Given this list of marker genes RPA2, ARHGEF12, SNX10, ATOH1 (atonal bHLH transcription factor 1), ZC3H7A (zinc finger CCCH-type containing 7A), CCDC146, CXCR6, HAVCR2 (hepatitis A virus cellular receptor 2), LONRF3, GABBR1, PROS1, ERN1, PLEKHM3, TBX21, SLC2A3, MMP25, PRDM1, FCGR2B, RPL39L, XDH, RHBDF2, MYO1F, DOCK5, HOPX, POLK, GPHN, GNGT1, PTPRJ, TTC39C, ZEB2, LPIN1, ALCAM, TEF, SLC33A1, CADM3, ATP2B4, ATXN1, IFNAR2, COBLL1, RDM1, ITGA4, CX3CR1, PRF1, RUNX2, ESM1, MICAL2, ITGB2 (integrin subunit beta 2), KLRC2, LATS2, LGALS3, KIF5C, ITGB1, MS4A4A, NEBL, DAPK2, HDHD5, SMYD1, EEA1, IL18RAP, ITGA1, CCR2, FRRS1, GVINP1, IKZF3, GSAP, ITGAM, GNPTAB (NCBI Gene Id 79158), OSBPL3, NRP1, NFIL3, IFNG, PFKP, RAP1B, STARD10, DCLRE1A, ADGRE5 (adhesion G protein-coupled receptor E5), NKG7, KLRC3, CYRIA, MYADM, BHLHE40, ITGAL, ARRDC3, F2RL2, GNA15, CALM2, MIR202, GIMAP4, AHNAK, HIP1, MYO5A, ANXA1 (NCBI Gene Id 301), ARHGAP18, RSU1, CYTH4, RORA (RAR related orphan receptor A), MLKL, H2AZ1, SEPTIN10, TSPAN2, ZDHHC2, ARL15, EBPL, TMEM65, PTBP2, XYLT1, KCNJ8, SMPDL3B (sphingomyelin phosphodiesterase acid like 3B), EHBP1L1, VIM, ID2, GZMK, GSPT2, CMKLR1, SOAT2 (NCBI Gene Id 8435), MOSPD1, FGL2, LRRK1, PCGF2, WDR49, TMEM37, FIBP, CYFIP1, TNFRSF1B, EMP1, CCDC50, GPRIN3, CHIC1, CYP17A1, ITGAX, IL12RB2, RGS1, CDC20B, TMEM163, PIK3CG, IL2RA, TRIM46, CHPT1, ARSB, CTSD, EMP3, CD226, CCL5, KLRK1, CD44, ELL2, RNF216, TTC7B, BCL2L1, L1CAM, TOB2, CDHR1, CCL4, SRCIN1, CORO2A, TTC39B, LAIR1, SEMA4F, IL1RL1, IL18R1, PPT1, ARL4C, CERS4, here is a description of the gene set: from publication Hammer M, Mages J, Dietrich H, Servatius A, Howells N, Cato AC, Lang R (PMID 16380512) Activation of the Mitogen activated protein kinase (MAPK) cascade following Toll-like receptor (TLR) stimulation enables innate immune cells to rapidly activate cytokine gene expression. A balanced response to signals of infectious danger requires that cellular activation is transient. Here, we identify the MAPK phosphatase Dual specificity phosphatase-1 (DUSP1) as an essential endogenous regulator of the inflammatory response to LPS. DUSP1-deficient (DUSP1-/-) bone marrow derived macrophages showed selectively prolonged activation of p38 MAPK and increased cytokine production. Intraperitoneal challenge of DUSP1-/- mice with LPS caused increased lethality and overshooting production of IL-6 and TNF-alpha. Transcriptional profiling revealed that DUSP1 controls a significant fraction of LPS-induced genes, that includes IL-6 and IL-10 as well as the chemokines CCL3, CCL4 and CXCL2. In contrast, the expression of the important mediators of endotoxin lethality, IFN-gamma and IL-12, was not significantly altered by the absence of DUSP1. These data together demonstrate a specific regulatory role of DUSP1 in controlling a subset of LPS-induced genes that determines the outcome of endotoxin shock. Genes up-regulated in untreated spleen: DUSP1 knockout versus wildtype. species: Homo sapiens Human Gene Set: GSE3565_DUSP1_VS_WT_SPLENOCYTES_UP